The following is a description of a gene set: species: Homo sapiens Any process that results in a change in state or activity of a cell or an organism (in terms of movement, secretion, enzyme production, gene expression, etc.) as a result of a stimulus from a virus. Human Gene Set: GOBP_RESPONSE_TO_VIRUS, and this is the list of marker genes: USP17L2, MIR26B, CCL11, SPN, TRIM38 (tripartite motif containing 38), VAMP8, CHRM2, IRGM, PLA2G10, RIPK3, BCL2L1, SHFL, BST2, TREX1, CHMP3, IL23A, IKBKG, MX2, IL1B, AGBL4, CCL22, RPSA, RNASE6, CXCR4, MAVS, UAP1 (UDP-N-acetylglucosamine pyrophosphorylase 1), IFNA21, TLR9, IFNG, BANF1, TRAF3, RNASEL, IRAK3, OTUD4, ATG16L1, EXOC1, RPS15A, FOSL1, TLR2, HIF1A, CCL19, OAS3, IFNA6, NMBR, ARF1, POLR3G, JAK1, MIR302A, BAX, DHX9, RAB2B, IVNS1ABP, CD207, FMR1 (fragile X messenger ribonucleoprotein 1), IFIT2, CD40, MIR758, MIR29B1, ILRUN, NDUFAF4, ZBP1, USP18, IFNA10, ZCCHC3, NLRP3, MIR146A, ISG15, TRIM25, IRF1, GBP1, ATF2, BCL3, CALR, IFITM2, APOBEC3F, BCL2, MMP12, TICAM1, BNIP3L, TRIM5, AZU1, HES1, TARBP2, TRIM26, MST1R, IFIT5, IRF3, APOB, ADARB1, IFI44, MARCHF2, CARD9, ISG20, RTP4, RNF216, MIR130A, HSP90AA1, EIF2AK4, DDX3X, POLR3C, TNF, AIMP1, ZMYND11 (NCBI Gene Id 10771), IRF7, F2RL1, G3BP1, HYAL2, DDX56, TPT1, SLFN13, IFIT1, IFNGR2, AKAP1, TRIM34, SAP30BP, SMPD1, TRIM13, IFITM1, CXCL10, ILF3, ZDHHC11, TRIM22, CDK6, UNC93B1, TBK1, DDIT4, MIR30C1, TRIM6, HCFC2, RHEB, TLR8, SIN3A, MID2, FGR, USP27X, PARP9, IFNA4, DTX3L, HYAL3, TBX21, WDFY4, CXCL12, TRIM56, FADD, CCL4, GARIN5A, ZC3HAV1, DHX16, IFNA8, DDX1, TRIM28, HERC5, TANK, TRIM21, AUP1, URI1, NLRP9, SELENOK, C1QBP, RSAD2, MUL1, ACOD1, ZDHHC1, TGFB1, IFNL4, ZNF175, EXOSC4, VAPB, IL12A, IFNB1, IFI16 (interferon gamma inducible protein 16), NMB, CXADR, NMI, MIR21, IFNA2, FCN3, GATA3, TRIM35, MICA, RRP1B, IRF9, LGALS8, TRIM11, USP29, ATAD3A, TNFAIP3, GBP3, DHX15, GTF2F1, PRF1, IFNL2, PQBP1, LSM14A, IFNA14, CD37 (NCBI Gene Id 951), CREB3, LILRB1, MTOR, UBE2N, VWCE, UBL7, TOMM70, ZDHHC11B, ATG12, TRIM27, TTC4, TRAF3IP2, DEFA1, MAPK14, HNRNPUL1, CD2AP (CD2 associated protein), BTBD17, NCK1, IFIT3, APOBEC3A, ELMOD2, CARD8, ZC3H12A, ARMC5, IFI27, NCBP3, SKP2, TRAF6, NLRP6, IFIH1, DHX58, IL23R, BPIFA1, PYCARD, IFI44L, MLKL, UNC13D, ATG5, LGALS9, ITGB8, CXCL9, EIF2AK2, RIOK3, DNAJC3, IFNLR1, DMBT1, SETD2, DUS2, SMARCA5, DEFA3, ITGAX, APOBEC3H, GSDME, ZMPSTE24, NLRP1, CFL1, CCL8, RNF135, AP1S1, SERINC5, APOBEC3B, ITCH, ENO1 (enolase 1), IFNAR2, IL10RB, OPRK1, STAT1, SLFN11, PIM2, IL33, IFNA17, RNASE2, XCL1, FOXP3, AGBL5, POLR3A, MAPK11, EPG5, IFIT1B, IFNGR1, CLU, FGL2, APOBEC3D, NFKB1, POU2F2, BATF3, CCDC92 (NCBI Gene Id 80212), STAT2, ABCC9, IFNAR1, IFNA16, PCBP2, EXOSC5, TRAF3IP1, IL21, IFNK, APOBEC3C, ATG14, IL12RB1, SAMHD1, CNOT7, ZNFX1, DCLK1, RNASE1, KCNJ8, RNF185, TRIM44, DDX60L, PLSCR1, RNF26, EXT1, POLR3K, NLRC5, IFNA7, UBE2W, LAMTOR5, EIF5A, HEATR9, ERCC6, HYAL1, EEF1G, POLR3D, GBP5, ODC1, DHX36, AICDA, TBKBP1, APOBEC3G, DEFA1B, SENP7, PENK, PHB1, TRIM15, IRF5, IFNW1, GBF1, PHB2, PPM1B, IL17RA, CHUK, DDX60, STING1, IL6, PML, MBL2, IFNL3, HMGA2, NT5C2, CRCP, TLR7, IFNE, DDX17, MOV10, IFITM3, DDX21, MIR675, OAS1, IFNA1, GPR146, IKBKE, MORC3, LYST, MAP3K14, GBP2, TRIM7, IL15 (NCBI Gene Id 3600), STMN1, PDE12, MICB, CLPB (ClpB family mitochondrial disaggregase), BECN1, TMEM120A, GPAM (NCBI Gene Id 57678), TRIM65, CGAS, TRIM41, PMAIP1, JAK2, TSPAN32, ADAR, TRIM31, OASL, RIGI, POLR3F, TYK2, RELA, NCBP1, GLI2, PTPRC, TLR3, LCN2, GPR108, XPR1, POU2AF1, PSMA2 (NCBI Gene Id 5683), BNIP3, TRIM32, AIM2, ABCF3, PYDC5, IFI6, ITGB6, RB1CC1, YJU2B, HSPB1 (NCBI Gene Id 3315), TRIM8, IKBKB, SERINC3, SMAD3, POLR3H, SPON2, POLR3E, CCT5 (NCBI Gene Id 22948), ACTA2, IRF2, PRKRA, TRIM52, ATG7, SLC38A8, DUOX2, USP44, DDX41, GBP7, HDAC6, IFNA5, MYD88, TNFSF4, OAS2, CCL5, SEC11A, MX1, IFNL1, NPC2, AZI2, NT5C3A, CASP1, IL27, IL12B, USP20, CREBZF, POLR3B